The following is a description of a gene set: Genes negatively differentially expressed in cell type: NK cell upon treatment with cytokine: IL-10 in mouse lymph nodes in vivo. Cytokines mediate cell-cell communication in the immune system and represent important therapeutic targets. A myriad of studies have highlighted their central role in immune function, yet we lack a global view of the cellular responses of each immune cell type to each cytokine. To address this gap, the authors created the Immune Dictionary, a compendium of single-cell transcriptomic profiles of more than 17 immune cell types in response to each of 86 cytokines (>1,400 cytokine-cell type combinations) in mouse lymph nodes in vivo. A cytokine-centric view of the dictionary revealed that most cytokines induce highly cell-type-specific responses. For example, the inflammatory cytokine interleukin-1β induces distinct gene programmes in almost every cell type. A cell-type-centric view of the dictionary identified more than 66 cytokine-driven cellular polarization states across immune cell types, including previously uncharacterized states such as an interleukin-18-induced polyfunctional natural killer cell state. Mouse Gene Set: CUI_NK_CELL_IL10_RESPONSE_DN studied in species Mus musculus from publication Cui A, Huang T, Li S, Ma A, Pérez JL, Sander C, Keskin DB, Wu CJ, Fraenkel E, Hacohen N (PMID 38057668), and this is the list of marker genes: Cd7, Rgs1, Ubc, Eef2, Fuca1, Shisa5, Jun, Bcl2, Tnfaip3, Rhob, Il18r1, Klf6, Txk, Itm2a, Tecpr1, S100a10, Dusp1, Ctla2a, Cma1, Uba7, Klrd1, Supt4a, Ccl5, Ltb, Jak1, Evl, Ndufa6, Ypel3, Mxd4 (Max dimerization protein 4), Ramac, Btg2, Tsc22d3, Cox7a2l, Klf2, Clk1, Cd96, Uba52, Peli1, Pnrc1, Neurl3, Junb, Fryl, Grap, Zfp36l2, Trbc1